The following is a description of a gene set: Mouse Gene Set: GOMF_DEOXYNUCLEOSIDE_PHOSPHATE_KINASE_ACTIVITY_ATP_AS_PHOSPHATE_DONOR Catalysis of the reaction: a 2'-deoxyribonucleoside 5'-phosphate + ATP = a 2'-deoxyribonucleoside 5'-diphosphate + ADP. species: Mus musculus, and this is the list of marker genes: Ak4, Ak1, Dtymk, Cmpk1, Cmpk2